Given this list of marker genes Ppp4r3c1, Ppp4r3a, Ppp4r3b, Ppp4r3c2, Ppp4r2, Ppp4c, here is a description of the gene set: A protein serine/threonine phosphatase complex formed by the catalytic subunit of protein phosphatase 4 plus one or more regulatory subunits. species: Mus musculus Mouse Gene Set: GOCC_PROTEIN_PHOSPHATASE_4_COMPLEX